Given this list of marker genes FLI1, ELAVL4, TOR1AIP2, CTSK, ITGA5, HOXB4 (NCBI Gene Id 3214), RNF220, PLCB3 (phospholipase C beta 3), GRIN2B, RAD23B, CPNE6, NDRG2, GLYR1, ITGB8, FOXA2, THBS3, MEOX2, HNRNPR, BRMS1L, DHH, GNAO1, FBXL20, PLP2, CYLD, CPNE1, CELF4, AHCYL1, MLLT10, PCF11, LRP1, CLC, ATG12, KCNN3, BCL6B, ASB2, NEUROD2, FBXO36, CBX8, SUPT16H (NCBI Gene Id 6831), USP32, GNB2, IGFBP5, SLC12A5, TMEM150A, CACNG2, CADM1, EBF1, PURG, TNFRSF8, IMPDH1, GNAZ, ARHGAP5, SYNPO2L, FILIP1, ZNF462, JPH2, FBRS, HOXB2, PPP1CB, TNPO2, FGF20, PPP3CB, FBXO11, NCDN, CLTC, CDK12, PABPN1, ZDHHC22, PHACTR3, ZNF516-DT, S100A16, PPFIA2, RBM12, KRT16, PPP1R1B, OVOL1, ITPKC, VIM, SP7 (NCBI Gene Id 121340), C1orf122, IL27, VWF, GPR173, PSTPIP1, MAP1A, PICALM, HMBOX1, NKX2-2, LIN28A, SZRD1, PRKCE, BARHL1, BRWD3, ING3, INTS3, C8orf33, RAB11B, IGF2BP1, POU3F3, STAG2, RBL1, MMP13, YRDC, MYL3, SLITRK4, MARK2, OTX2, EP300, COLGALT2, TRIM62, EIF4G1, LBX1, NYAP1, SUSD1 (sushi domain containing 1), NUFIP2, SP4, PHF21B, CASZ1, OAZ2, PURA, LUC7L3, WRN, HOXA3, GOT1 (NCBI Gene Id 2805), ADNP, MYH7, TEAD2, ST7, BDNF, CALM1, PLCB1, TIMP3 (NCBI Gene Id 7078), MORF4L2, PIH1D2, DCTN1, MTX1, SDR39U1, NKAPD1, MXI1, NUAK1 (NCBI Gene Id 9891), RAD23A, HSD17B8, CALM3, AP3S1, KLF12, RALBP1, INTS9, KCNJ13, ARX, KPNB1, SASS6, RBM39, DLX1, ARHGAP45, S100A14, GRIN2D, MCTS1, AUTS2, UBE2E1, TRIM46, CAPN12, FMNL3, GPR158, FLNC, C1orf43, BAHD1, EPO, PLXNB3, BBX, ZNF485, EMX2, KRTCAP2, ARL4C, NOVA2, GSPT2, ID4, NFATC4, PNKD, TRERF1 (transcriptional regulating factor 1), EGR3, RERE, SIK2, ZNF532, HOXB8, DLL4, RUNX1, JADE2, FTHL17, NTRK3, SP1, FES, KCNA1, HOXC11, IGSF21, HNRNPA0, BCL9, NPR3, NRG1, TSPAN7, HIBADH, ZBTB9, AKIRIN2, RBMS1, ZNF385A, TRMT13, AAMP, COQ8B, NALF2, TBCC, ZNF821, here is a description of the gene set: Human Gene Set: RREB1_01 Genes having at least one occurrence of the motif CCCCAAACMMCCCC in the regions spanning 4 kb centered on their transcription starting sites. This matches the RREB1 transcription factor binding site V$RREB1_01 (v7.4 TRANSFAC). species: Homo sapiens